Given this list of marker genes PDX1 (NCBI Gene Id 3651), RRAGD, SESN3, PIK3CA, MTOR, UBR1, LARS1, RPTOR, KLHL22, STAMBPL1, EP300, UBR2, SESN1, PIK3C3, SESN2, here is a description of the gene set: species: Homo sapiens Any process that results in a change in state or activity of a cell or an organism (in terms of movement, secretion, enzyme production, gene expression, etc.) as a result of a L-leucine stimulus. Human Gene Set: GOBP_RESPONSE_TO_L_LEUCINE